Given this list of marker genes Igsf9, Socs2, Abr, Zfp764, Zfp516, Tmem178b, Spty2d1, Zfp11, Hipk3, Hnrnpd, Amd2, Stx12, Lyn, Snx12 (NCBI Gene Id 72081), Slfn9, Tfap2b, St18, Ppm1h, Zfta, Kics2, Khdc1b, Prodh2, Drd1, A430033K04Rik, Amd1, Ehd4, Mapk9, Ak3, Shank2, Pik3cd, Ifnlr1, Acta2, Seh1l, Hsdl1, Clock, Trp53inp1, Zfp810, Srsf2, Cntn1, Uncx, Camk1d, here is a description of the gene set: Genes predicted to be targets of miRBase v22 microRNA mmu_miR_6955_3p in miRDB v6.0 with MirTarget v4 prediction scores > 80 (high confidence targets). Mouse Gene Set: MIR_6955_3P species: Mus musculus from publication Chen Y, Wang X (PMID 31504780)